The following is a description of a gene set: from publication Wang Z, Iwasaki M, Ficara F, Lin C, Matheny C, Wong SH, Smith KS, Cleary ML (PMID 20541704) Genes up-regulated in RS4;11 cells (MLL, mixed lineage leukemia) in response to SB216763, an inhibitor of GSK3B. Acute leukemias induced by MLL chimeric oncoproteins are among the subset of cancers distinguished by a paradoxical dependence on GSK-3 kinase activity for sustained proliferation. We demonstrate here that GSK-3 maintains the MLL leukemia stem cell transcriptional program by promoting the conditional association of CREB and its coactivators TORC and CBP with homedomain protein MEIS1, a critical component of the MLL-subordinate program, which in turn facilitates HOX-mediated transcription and transformation. This mechanism also applies to hematopoietic cells transformed by other HOX genes, including CDX2, which is highly expressed in a majority of acute myeloid leukemias, thus providing a molecular approach based on GSK-3 inhibitory strategies to target HOX-associated transcription in a broad spectrum of leukemias. Human Gene Set: WANG_RESPONSE_TO_GSK3_INHIBITOR_SB216763_UP studied in species Homo sapiens, and this is the list of marker genes: SORL1, NCF2 (NCBI Gene Id 4688), SND1-IT1, USO1, ADGRE4P, CYB561A3, MGAT4A, HERC2P4, DNASE2, THG1L, CFAP144P1, ARRDC3, ABRAXAS1, IPCEF1, ZNF404, GAA, ZNF280D, MEFV, KMT2C, CD47, FGGY, SGTB, SNORD116-6, HERC2P2, ANKRD18A, SAT1, RHOU, CSTA, ST3GAL2, SYCP2L, AP1G2, ZNF138, AHCYL2, PTPN22, RPL21P93 (ribosomal protein L21 pseudogene 93), SLC35D2, QSOX1, AMPD3, TNFAIP2, LPAR2, CD68, PUS10, TPT1P9, MCOLN2, SNORD116-3, CTSH, TLR1, CSNK2A2, PARP10, TPTE2, CXCR4, TIMP2, NFKB2, SLC7A11, MYO15B, NPIPB7, ZNF581, LTA4H, CASP1, ACAD11, PHF21A, TRA2A, ZNF555, DMXL2 (Dmx like 2), P2RX4, PLSCR1, ZYG11B, SLC17A5, TCAIM, ADCY10P1, ATP6V1A, ST14, CTNND1, KLHDC1, CD84, SIGLEC10, FYB1, ZNF230, NAGLU, LAMP1, ATP6AP1L, GOLGA1, RCAN3, DUSP5P1, SLX4IP, MR1, TXK, RNF130, PRKAR2B, MCMDC2, ZNF91, TTC17, TRIM38 (tripartite motif containing 38), TMEM198B, ITGB7, DPH5, DCP1B, RSRP1, RASGRP4, CREB5, ZNF366, ACER3, ALCAM, CCDC144A, MYOM1 (myomesin 1), PAN2, TAF12, FAM220A, GM2A, OMA1, SLC46A3, DNAJC4, PARP9, PAQR8, GTF2IRD2, H2BC18, XAF1, MGST1, ATP7A, SNHG32, TBC1D3G, STAT2, OTULINL, ATF7, RPL21, ZNF577, RCBTB2, HPS1, MANBA, C18orf32, FLVCR2, SNX29P2, MS4A7, ZC3H6, MYO18A, NAIP, PIP4P2, SLC25A20, AMY2A, TTLL3, SENP7, HLA-DMA, SNORD116-8, RPL12P2, PROS1, IDS (iduronate 2-sulfatase), ATXN1, PWAR5, GIPR, ANO8, NKG7, TMEM131, SLC15A2, FIG4, SAT2, ACSF2, SLC25A6P2, LIMD1-AS1, STXBP1, SAMD8, NEU1, HPD, GNS, GSTM4, ALG13 (NCBI Gene Id 79868), SCARNA17, TET2, FOXN2, SPTAN1, PRCP, SCIMP, TAS2R4, ABCA7, NCAM2, LRRC37A, CTSB (cathepsin B), PITPNC1, ST8SIA6, LHFPL2, MFSD13A, PLD3, SLC38A6, ATP10D, GNPDA1, AFG1L, MALAT1, PIP5K1A, PIK3R3, ADA2, ZNF573, POLR1HASP, PRKCB, DAPP1, ARNT, SIDT2, IL18, DTNA, CD48, ZNF93, RPRD2, SEZ6L2, LETMD1, FRRS1, CD300LF (NCBI Gene Id 146722), ERV3-1, R3HDM2, C5, AMY2B, CTSS, AGTPBP1, LINC01002, TEX19, ATG4C, ZNF252P, DENND1C, TMEM86A, GBGT1, MYO5A, SERINC5, GIMAP2, ZNF429, PDE1B (NCBI Gene Id 5153), CSF3R, PSAP, IGF1, ATF7IP2, C14orf93, ATG16L2, GPAT3, TBC1D3C, SCARNA9, LRMDA, HERC2P3, ITCH, LRRC37A2, PTPRC, NPC1, CACNA1E, ANKRD26, CD4, ZMAT3, PCNX1, ZNF117, SEC31B, TRAF3IP3, VIT, ALDH2, TMEM260, RPL31, ZNF251, ARL3, CHD2, GBA1LP, CD74, CCNI (cyclin I), SLC37A2, ELMO1, HEXB, RNF213, CPEB4, SNRPN, OR7E85BP, TBC1D3B, MTHFD2, TMEM144, RHOT1, TMEM62, CARF, BTN2A2, NBEAL1, VPS8, ENPP2, EVI2A, ASAH1, CAMLG, FGD2, ANKRD20A2P, SNORD116-1 (NCBI Gene Id 100033413), IL10RB, LIG4, KCNE3, CCDC146, CCNB1IP1, RNU105C, STAG3L4, DENND4B, CD36, SSBP2, ZFAND1, NABP1, AMY1A, KDM4A, WASHC2A, CLN8, RPL28, ABAT, SNORD58A, SNORD49B, RCOR3, SLC2A9, ZNF641, LRRC37A4P, ZFAS1, EFHC1, BBS2, IL10RA, AGL, JAML, ACRBP, PLXDC2, ANXA5, F11R, WASHC2C, SDCCAG8, LY86, BLTP1, RRAGD, COLGALT2, KRBOX4, NCF4, TNFSF13B, CD101, KIAA0825, ARL17A, ZFYVE16, CIMAP1B, GFRA2, EPB41L4A-AS1, C1RL, CDK5RAP3, STAC3, HACD4, GLRX, B2M, DMXL1, EVI2B, CRYBG1, ZNF226, RPL23AP82, TRAPPC2, TRAF3IP2, FGL2, PAPSS1, KRCC1, SCAPER, PAFAH2, TMEM106B, IFIH1 (NCBI Gene Id 64135), ANKRD20A8P, GRAMD2B, IFI30, RFT1, SCARB2, AMZ2P1, CD37, DZIP3, NLRC4, VWA8, BBS10, LDAF1, NBR2, SHISA7, PSTPIP2, ATP8B4, SIGLEC6, SESN3, SKIC3, MAP4K1, TAF1D, SNORD116-24, ARHGAP15, ALOX5AP (arachidonate 5-lipoxygenase activating protein), DYM, ZNF277, ORMDL1, GPHN, TRAK2, GCNT1, PLD1, LIMA1, EIF4B, SNX29P1, FUNDC1, PRDM1, IGFLR1, HOMEZ, VEGFA, SIRPB2, CPT1B, SPATS2, ZFAND3, SNORD116-5